Given this list of marker genes GRB2, ADCY1, CFL1, SOS1, HRAS, SYNE4, ADCY4, YY1AP1, MAPK1, SMAD3, SOS2, ADCY2 (NCBI Gene Id 254679), SYNE1, TGFB3, KIF5B, CCN2, ADCY3, EMD, TGFB2, SRF, NRAS, SMAD4, MAP2K1, ADCY7, MAP3K9, SUN1, SYNE3, TMPO, PLEC, TGFB1, ADCY9, ADCY5, LEMD3, SMAD2, WWTR1, SYNE2 (NCBI Gene Id 26075), ADCY6, TMEM43, MAP2K2, ADCY8, KRAS, BANF1, RHOA, ADCY10, LBR, MAPK3, here is a description of the gene set: Envelope proteins and their potential roles in EDMD physiopathology species: Homo sapiens Human Gene Set: WP_ENVELOPE_PROTEINS_AND_THEIR_POTENTIAL_ROLES_IN_EDMD_PHYSIOPATHOLOGY